The following is a description of a gene set: Human Gene Set: GOMF_3_5_EXONUCLEASE_ACTIVITY Catalysis of the hydrolysis of ester linkages within nucleic acids by removing nucleotide residues from the 3' end. studied in species Homo sapiens, and this is the list of marker genes: ISG20L2, PAN3 (NCBI Gene Id 376186), EXD1, ERI3 (ERI1 exoribonuclease family member 3), EXOSC7 (exosome component 7), TREX1, CNOT6L, PARN, TATDN1, PNLDC1, XRN2, APEX2, USB1, TREX2, EXOSC5, POLD1, TRIR, EXOSC3, EXD3, REXO2, MYG1, TOE1, RAD1, APLF, POLRMT, ERI1, MRE11 (NCBI Gene Id 4361), POLE, DIS3, DIS3L2, DIS3L (DIS3 like exosome 3'-5' exoribonuclease), EXOSC9, POLG, NME8, CNOT1 (CCR4-NOT transcription complex subunit 1), MEIOB, NME7, EXOSC4, CNOT7, PNPT1, ISG20, CNOT6, EXOSC10, REXO4, NOCT, RAD9A, HELZ2, ERI2, CNOT2, NME1, WRN, RAD50, PDE12, APEX1, CNOT8, NME5, PAN2, EXD2, EXO5, EXOSC2 (exosome component 2)